Given this list of marker genes Notch1, Tsc22d1, Tfcp2l1, Ndn, Klf9, Gata6, Bach1, Egr1 (NCBI Gene Id 13653), Nab2, Ar, Mllt3, Hic1, Dlx5, Pax9, Esr1, Arnt2, Hand2, Satb1, Hr, Fos, Hoxa4, Tead1, Zfp37, Zfp14, Pbx3, Pax5, Hdac5, Nr1h3, Tead2, Arx, Klf6 (Kruppel-like transcription factor 6), Zfp422, Spib, Jun, Smad1, Cavin1, Foxb1, here is a description of the gene set: Selected genes down-regulated in the TLX1 Tet On iEBHX15-4 cells (pro-erythroblasts) at 12 h time point. species: Mus musculus from publication Riz I, Akimov SS, Eaker SS, Baxter KK, Lee HJ, Mariño-Ramírez L, Landsman D, Hawley TS, Hawley RG (PMID 17213805) Aberrant expression of the human homeobox-containing proto-oncogene TLX1/HOX11 inhibits hematopoietic differentiation programs in a number of murine model systems. Here, we report the establishment of a murine erythroid progenitor cell line, iEBHX1S-4, developmentally arrested by regulatable TLX1 expression. Extinction of TLX1 expression released the iEBHX1S-4 differentiation block, allowing erythropoietin-dependent acquisition of erythroid markers and hemoglobin synthesis. Coordinated activation of erythroid transcriptional networks integrated by the acetyltransferase co-activator CREB-binding protein (CBP) was suggested by bioinformatic analysis of the upstream regulatory regions of several conditionally induced iEBHX1S-4 gene sets. In accord with this notion, CBP-associated acetylation of GATA-1, an essential regulator of erythroid differentiation, increased concomitantly with TLX1 downregulation. Coimmunoprecipitation experiments and glutathione-S-transferase pull-down assays revealed that TLX1 directly binds to CBP, and confocal laser microscopy demonstrated that the two proteins partially colocalize at intranuclear sites in iEBHX1S-4 cells. Notably, the distribution of CBP in conditionally blocked iEBHX1S-4 cells partially overlapped with chromatin marked by a repressive histone methylation pattern, and downregulation of TLX1 coincided with exit of CBP from these heterochromatic regions. Thus, we propose that TLX1-mediated differentiation arrest may be achieved in part through a mechanism that involves redirection of CBP and/or its sequestration in repressive chromatin domains. Mouse Gene Set: RIZ_ERYTHROID_DIFFERENTIATION_12HR